The following is a description of a gene set: mouse primary BMDCs were stimulated with tlr ligands and gene expression changes were profiled on Affymetrix arrays Genes down-regulated in comparison of control dendritic cells (DC) at 8 h versus those stimulated with Pam3Csk4 (TLR1/2 agonist) at 8 h. species: Homo sapiens from publication Amit I, Garber M, Chevrier N, Leite AP, Donner Y, Eisenhaure T, Guttman M, Grenier JK, Li W, Zuk O, Schubert LA, Birditt B, Shay T, Goren A, Zhang X, Smith Z, Deering R, McDonald RC, Cabili M, Bernstein BE, Rinn JL, Meissner A, Root DE, Hacohen N, Regev A (PMID 19729616) Human Gene Set: GSE17721_CTRL_VS_PAM3CSK4_8H_BMDC_DN, and this is the list of marker genes: CHRNA3, MYBL1, GCA, FLG, TAGLN2, PTGR3, COX17, ZFAND3, ZNG1B, METAP1, ACTN3, KMT2D, TRAF5, AKAP7, MAPKAPK5, PTPN11, SFXN1, SLTM, TBCA (NCBI Gene Id 9549), POGLUT1, ZBTB7A, ADAMTS7, SCX, CD70, HOXA9, DLC1, ZC3H18, POLR2C, SLC28A2, TACR2, ATP6V1E1, CPD, YARS1, SOCS1, SOD2, HDAC1, C11orf71, SMAD9 (SMAD family member 9), ASB6, SNX16, KLF5, KRT16, PSMD6, CYFIP2, WDR46, PSMA2, SUPT16H, SRXN1, CHTOP, DLGAP4, TEX19, SERPINE1, SLAMF1, PALLD, KCMF1, NKX2-1, SLPI (NCBI Gene Id 6590), GUCD1, RUSC2, CHMP2A, DTNB, DNAJB11, VCP, DHX38, RBM8A, CCND2, USO1, ADCYAP1, REV1, PACS1, GBP2, CCT7 (chaperonin containing TCP1 subunit 7), GDI1, TRMT112, TAL1, GNB1, GTF2E2, ELL2, RGL1, PDE4B, GINM1, MAP3K8, GRB2, PPT2, IL10RB, CHST7, GRAMD1A, DNAJC1, NUDT9, CLEC4D, PTPRN2 (protein tyrosine phosphatase receptor type N2), PUM3, TMEM38B, NRG4, NME6, FKBP1A, GPSM1, ARHGEF2, AHR, SRSF9, TADA2A, CAPRIN1, SCRT1, ASNS, LMO4, RPS6KA2, UCN, ABCB11, NOL7, BRAF, B3GALT5, AGBL5, FGF7, SQOR, RAI14, HNRNPAB (NCBI Gene Id 3182), C1orf35, USP47, REG1B, EMC2, PDZK1IP1, MAPK6, TMOD1 (tropomodulin 1), ATOSB, RLN1, KMT5A, REPS1, GSR, PKP4, PDE1A, IKBKB, EGLN3, RASA2, CLEC5A, ARG2, PRKCZ, ELAPOR1, FCGR2B, PJA2 (praja ring finger ubiquitin ligase 2), MAS1, KDELR2, PLK2, APOA5, GFPT2, BRWD3, RABGGTB, DACH1, TBK1, MECP2, SLAMF6, ARFGAP3, POFUT2, SERPINA12, TTC39C (tetratricopeptide repeat domain 39C), ADGRL4, MAST1, UTY, ARTN, KCNS2, TDRD7, PELI1, AMELX, SEC24D (SEC24 homolog D, COPII coat complex component), BAG5, LAMB3, MDFIC, PPP1R14B, FAM81A, CACNA1D, POU2F2, TMPRSS3, DPYSL2, FXR2, ORM1, MAPK11, HTRA2, CHRDL1, CEP250, GRPEL2, PELP1, KRT27, LIG3, CRX, DOC2A, VAC14 (NCBI Gene Id 55697), FBXW11, HMOX1, METTL3, DHPS, NOTCH1, TTR (transthyretin), SLC2A1, COL4A2 (NCBI Gene Id 1284), FADD, ATF7IP2, ICOSLG, IPO4, CLIP1, NELL2, PSCA